The following is a description of a gene set: studied in species Mus musculus Cytokines mediate cell-cell communication in the immune system and represent important therapeutic targets. A myriad of studies have highlighted their central role in immune function, yet we lack a global view of the cellular responses of each immune cell type to each cytokine. To address this gap, the authors created the Immune Dictionary, a compendium of single-cell transcriptomic profiles of more than 17 immune cell types in response to each of 86 cytokines (>1,400 cytokine-cell type combinations) in mouse lymph nodes in vivo. A cytokine-centric view of the dictionary revealed that most cytokines induce highly cell-type-specific responses. For example, the inflammatory cytokine interleukin-1β induces distinct gene programmes in almost every cell type. A cell-type-centric view of the dictionary identified more than 66 cytokine-driven cellular polarization states across immune cell types, including previously uncharacterized states such as an interleukin-18-induced polyfunctional natural killer cell state. from publication Cui A, Huang T, Li S, Ma A, Pérez JL, Sander C, Keskin DB, Wu CJ, Fraenkel E, Hacohen N (PMID 38057668) Genes negatively differentially expressed in cell type: MigDC (migratory dendritic cell) upon treatment with cytokine: IL-1β in mouse lymph nodes in vivo. Mouse Gene Set: CUI_MIGDC_IL1B_RESPONSE_DN, and this is the list of marker genes: Gpr68, Laptm5, Cdc42ep3, Vrk2, H2-Q6, Nrbf2, Usp47 (NCBI Gene Id 74996), Abcg1, Emp3, Evi2a, Clptm1, Apol10b, Snrnp25, Slc6a6, Tubb5, Sec61b, Eno2, Zfp36l1, Ogt, Ucp2, Mx1, Tmem19, Fyb1, Ndnf, Man1a, Nup210, Fam32a, S100a6, Dek, Zfp524, Idh1, Tuba1c, Gtpbp1, Zmynd15, Tcf7l2, Ftl1, Usp18, Slc2a6, Josd1, Peli1, Mpeg1, Arhgap22, Nabp1, Csf2rb2, Brk1, Nxf1, Mmp23, Celf2, Dlgap4, Sned1, F11r, Itgb8 (integrin beta 8), Snrk, AU020206, Clip1 (NCBI Gene Id 97251), Slc38a2, Icosl (NCBI Gene Id 50723), Bcat2, Gbp9, Rgs3, Cep57, Vhl, Arhgap31, Mycbp2, Asap1 (NCBI Gene Id 13196), Atf7ip, Jmjd1c, Tmem158, Relb, Lmo4 (LIM domain only 4), Shtn1, Phf11b, Tnfrsf1b, Trim7, Gtf2a1, Eno3, Rassf4, Stard7, Ythdf2, H2az1, Mef2a, Reep3, Klf2, Jag1, Rubcn, Cyp27a1, Stk4, Pygl, Cyria, Got2, Haus8, Rcsd1, Rad50, Uvrag, Rasa4, Blnk, Cacnb3, Cblb, H1f2, Rbpms, Nav1, Pgap2, Ppp1r18, Sulf2, Apol7c, Cyba, Cd44, Sod1, Cat, Elk3, Lst1, Hmgcs1, Psap, Galnt12, Specc1, Ly86, Serf2, Dnm1l, Zc3h12c, Hck, Ramp1, Mylip (NCBI Gene Id 353050), Hspa1a, Ptpn6, Tmem150c, Gfpt1, Rab9, Aif1, Sh3bp1, Socs2 (suppressor of cytokine signaling 2), Fuca1, Dnajc5, Extl1, Cflar, Ptpn21, Kdm1b (NCBI Gene Id 218214, lysine (K)-specific demethylase 1B), Gpr157, Fdps, Wdr91, Gbp8, Hspa1b, Sema6d, Dynll1, Nfat5, Cxcl16, Limd2, Mxd1, St8sia6, Clec2i, Insm1, Nsmce3, Sik2, Ap1s3, Ctsh, Rtn4, Traf1, Adap1, Arl5c, Galnt1, Tmem176a, Enox2, Slc46a3, Cyfip2, Snx20, Arl5a, Zeb2, Chka (choline kinase alpha), Hivep1, Myo9b, Cdk17, Unc93b1, Tspan33, Nr3c1, Lamp1, Gsto1, Phf21a, Crip1, Sat1, Scamp2, Ttc7, Bri3, Swap70, Gpc1, Frmd4a, Kmt2c, Rab32, H2-Eb2, Tnfrsf11a, Slco5a1, Cpne2, Adm, Ccni, Adam23, Tm4sf5, Parp8, Atxn1, Zbtb20, Pbx1, Zc3h7b, Creg1 (NCBI Gene Id 433375), Anxa3, Tnfaip3, Glipr1, Tmcc3, Dpp4, Lyst, Ddhd1, Icam1, H2bc4, Dynll2, Fbrsl1, Tmem176b, Ankrd33b, Fosb, Hlx, Rptor, Casp3, Ankrd35, Il15, Trio, Nedd4, St8sia1, Syne1, Bmp2k (NCBI Gene Id 71114), Tank, Hmgcr, H2-M2, Rnf115